The following is a description of a gene set: The process in which peroxisomes are delivered to a type of vacuole and degraded in response to changing nutrient conditions. species: Homo sapiens Human Gene Set: GOBP_AUTOPHAGY_OF_PEROXISOME, and this is the list of marker genes: ACBD5, ATM, PJVK, PEX5, WIPI1, WDR45, SQSTM1 (sequestosome 1), USP30, WIPI2, ATG2A, RB1CC1, PEX2, PIK3C3 (phosphatidylinositol 3-kinase catalytic subunit type 3), PIK3R4, WDR45B, ATG2B